The following is a description of a gene set: species: Mus musculus Binds to and increases the activity of a cyclin-dependent protein serine/threonine kinase. Mouse Gene Set: GOMF_CYCLIN_DEPENDENT_PROTEIN_SERINE_THREONINE_KINASE_ACTIVATOR_ACTIVITY, and this is the list of marker genes: Ccnd3, Cks2, Mnat1, Ccnt2, Cdk5r1, Ccnt1, Ccnd2, Cdk5r2, Ccnd1, Tex24, Cks1b, Ccnb1-ps, Cks1brt, Ccnk, Ccnb1